Given this list of marker genes COLEC12, CLEC4G, SCARB1 (NCBI Gene Id 949), CLEC4A, CARD8 (NCBI Gene Id 22900), CD36, DMBT1, MARCO, ASGR2, AIM2, TRIM5, TLR8, CLEC4E, TLR3, PGLYRP4, PGLYRP3, CLEC4D (C-type lectin domain family 4 member D), CLEC7A, NLRP1, CD209, NLRP6, RIGI (RNA sensor RIG-I), CLEC4M, NOD2, TLR9, IFIH1, LY96 (NCBI Gene Id 23643), PGLYRP1, DHX16, TLR5, PYCARD, CLEC17A, NOD1, TLR2, CLEC4C, CD207, CLEC10A, PGLYRP2, TLR4, ASGR1, FCN1, CLEC6A, CLEC12A, FCER2, PTAFR, TLR7, CLEC4F, CD14, here is a description of the gene set: Combining with a pathogen-associated molecular pattern (PAMP), a structure conserved among microbial species to initiate an innate immune response. Human Gene Set: GOMF_PATTERN_RECOGNITION_RECEPTOR_ACTIVITY studied in species Homo sapiens